The following is a description of a gene set: Human Gene Set: GOBP_RENAL_SODIUM_ION_TRANSPORT The directed movement of sodium ions (Na+) by the renal system. species: Homo sapiens, and this is the list of marker genes: WNK3, SGK1, UMOD, SLC12A3, EDNRB, KLHL3, CLCNKB, KCNQ1, MAGED2, WNK4 (NCBI Gene Id 84361), NHERF1, OXSR1, EDN1, PON3, STK39, KCNJ1, ATP6V1B1, EDNRA, GUCA2B